The following is a description of a gene set: Hyperglycinuria species: Homo sapiens Human Gene Set: HP_HYPERGLYCINURIA An increased concentration of glycine in the urine., and this is the list of marker genes: PRODH, PCCA, SLC6A18, SLC6A20, IVD, ACADM, GLYCTK, PCCB, NFU1, SLC36A2, GLDC, ALDH4A1, MCCC2, SLC6A19